The following is a description of a gene set: Human Gene Set: REACTOME_PYRIMIDINE_CATABOLISM Pyrimidine catabolism studied in species Homo sapiens, and this is the list of marker genes: NT5M, NT5C1A, NT5C3A, NT5E, UPP1, UPB1, DPYD, AGXT2, TYMP, DPYS, NT5C (NCBI Gene Id 7370), UPP2